The following is a description of a gene set: Reactome Pathway: Mismatch repair (MMR) directed by MSH2:MSH3 (MutSbeta) species: Homo sapiens part of: Mismatch Repair MSH2:MSH3 (MutSbeta) binds unpaired loops of 2 or more nucleotides. Human cells contain about 6-fold more MSH2:MSH6 than MSH2:MSH3 (MutSbeta) and an imbalance in the ratio can cause a mutator phenotype. Binding of the mismatch activates MSH2:MSH3 to exchange ADP for ATP, adopt the conformation to allow movement along the DNA, and interact with downstream effectors PCNA, MLH1:PMS2 and EXO1. The interaction with PCNA initiates excision of the recently replicated strand. MLH1:PMS2 makes a nick that is enlarged to a gap of hundreds of nucleotides by EXO1. DNA is polymerized across the gap by DNA polymerase delta and the remaining nick is sealed by DNA ligase I., and this is the list of marker genes: LIG1, PCNA, POLD4, MLH1, MSH3, POLD2, RPA2, PMS2, POLD1, MSH2, EXO1, POLD3, RPA1, RPA3